The following is a description of a gene set: Human Gene Set: GOBP_VIRAL_TRANSCRIPTION The process by which a viral genome, or part of a viral genome, is transcribed within the host cell. species: Homo sapiens, and this is the list of marker genes: SP100, RRP1B, USF2, TAF11, SMARCB1, HPN, GTF2B, CCL3, POU2F3, BRD4, MID2 (midline 2), TRIM21, JUN, TRIM31, SNW1, CDK9, TRIM13, TRIM32, TRIM62, ZNF639, RSF1, CTDP1, TARBP2, LARP7, TFAP4, HDAC1 (histone deacetylase 1), CCNT1, REST, SMARCA4, PSMC3, TRIM14, TRIM8, SP1, TRIM11, ZFP36, IFITM3, MON1B (NCBI Gene Id 22879), MDFIC, TRIM27, NUCKS1, CHD1, EP300, HEXIM1, USF1, INPP5K, UBP1, LEF1, CCNT2, TARDBP, CCL5, CCL4, DHX9, HMGA2